Given this list of marker genes ADAR, SOCS1, CXCL10, IFITM3, HLA-C, IFI35, PIAS4, MXD4, IFI44, STAT1, IFI27, UBE2D3, E2F2, IRF7, PSME1, MX2, IL12RB2, PRKCQ, LGALS3BP, BRCA1, HLA-E, CALR, HLA-F, RFC2, AKR7A2, TNFSF10, RRP8, CASP3, PLSCR1, KLK3, IFITM2, PHB1, TUBB (tubulin beta class I), CDKN1B, CYB561D2, UBE2L6, CXCL11, IRF1 (interferon regulatory factor 1), ISG15, IFI44L, VCAM1, IFI6, MX1, IFITM1, BCL2, BST2, BAX, here is a description of the gene set: BACKGROUND & AIMS: Interferon (IFN)-alpha therapy is currently the primary choice for viral hepatitis and a promising treatment for hepatocellular carcinoma (HCC). Primary mouse and rat hepatocytes respond poorly to IFN-alpha stimulation. Thus, it is very important to examine the IFN-alpha signal pathway in primary human hepatocytes. METHODS: The IFN-alpha-activated signals and genes in primary human hepatocytes and hepatoma cells were examined by Western blotting and microarray analyses. RESULTS: Primary human hepatocytes respond very well to IFN-alpha stimulation as shown by activation of multiple signal transducer and activator of transcription factor (STAT) 1, 2, 3, 5, and multiple genes. The differential response to IFN-alpha stimulation in primary human and mouse hepatocytes may be caused by expression of predominant functional IFN-alpha receptor 2c (IFNAR2c) in primary human hepatocytes vs. expression of predominant inhibitory IFNAR2a in mouse hepatocytes. Microarray analyses of primary human hepatocytes show that IFN-alpha up-regulates about genes by over 2-fold and down-regulates about genes by 50%. The up-regulated genes include a variety of antiviral and tumor suppressors/proapoptotic genes. The down-regulated genes include c-myc and c-Met, the hepatocyte growth factor (HGF) receptor. Down-regulation of c-Met is caused by IFN-alpha suppression of the c-Met promoter through down-regulation of Sp1 binding and results in attenuation of HGF-induced signals and cell proliferation. CONCLUSIONS: IFN-alpha directly targets human hepatocytes, followed by activation of multiple STATs and regulation of a wide variety of genes, which may contribute to the antiviral and antitumor activities of IFN-alpha in human liver. Genes up-regulated in primary hepatocytes and Hep3B (hepatocyte) cells in response to IFNA. from publication Radaeva S, Jaruga B, Hong F, Kim WH, Fan S, Cai H, Strom S, Liu Y, El-Assal O, Gao B (PMID 11910354) studied in species Homo sapiens Human Gene Set: RADAEVA_RESPONSE_TO_IFNA1_UP